Given this list of marker genes CYP2C8, CYP3A4, CYP2U1, CYP1B1, CYP2C19, CYP1A2, CYP17A1, CYP39A1, CYP1A1, CYP11B2, CYP46A1, CYP3A43, CYP7A1, CYP2C9, CYP3A5 (NCBI Gene Id 1577), CYP11A1, CYP2R1, CH25H, CYP19A1, CYP11B1, CYP7B1, CYP8B1, CYP27A1, CYP2B6, CYP3A7, CYP24A1, CYP21A2, here is a description of the gene set: studied in species Homo sapiens Catalysis of the formation of a hydroxyl group on a steroid by incorporation of oxygen from O2. Human Gene Set: GOMF_STEROID_HYDROXYLASE_ACTIVITY